Given this list of marker genes I830134H01Rik, Prdx1, Gpr107 (G protein-coupled receptor 107), 2310022A10Rik, Mphosph6, Dynlt1a, Arl4a, Dynlt1b, Ptpn13, Ncor1, Ddb2, Prkd2, Zbtb45, Ndufa13, Pigl, Cpsf6, Stam, Cmtr2, Rrm2b, Odad1, Foxj3, Cep55, Magi3, Gnl2, Rfc2, Agpat3, Dop1b, Alkbh7, Gm12758, Mybl1, Phyh, Nfat5, Gm12762, Kat7, Cttn, 1700019D03Rik, Faf2, Cuedc2, Zfp563, Eea1, Cnpy2, Yjefn3, Chac2, Pprc1, Eef1e1, Mzf1, Mepce, Lama1, R3hcc1, Map9, Zfp868, Plscr1, Ndc1, Sars1, Eddm13, Pole2, Unk, Stamos (signal transducing adaptor molecule (SH3 domain and ITAM motif) 1, opposite strand), Fah, Snx1, Ttk, Frg2f1, Pcdhgb1, Gm11520, Myo1h, Flvcr1, Nutf2, Tomm40, Get4 (NCBI Gene Id 67604), Nt5dc1, Stat6, Rtca, Pld3, Srebf1, Nipsnap2, Ntan1, Morn2, Cass4, Gm12059 (NCBI Gene Id 100046833), here is a description of the gene set: Mouse Gene Set: ZFP456_TARGET_GENES from publication Yevshin I, Sharipov R, Kolmykov S, Kondrakhin Y, Kolpakov F (PMID 30445619) species: Mus musculus